The following is a description of a gene set: Mouse Gene Set: GOBP_RESCUE_OF_STALLED_RIBOSOME studied in species Mus musculus A process of translational elongation that takes place when a ribosome has stalled during translation, and results in freeing the ribosome from the stalled translation complex., and this is the list of marker genes: Gigyf2, Pelo, Cdk5rap3, Tcf25 (transcription factor 25 (basic helix-loop-helix)), Mrpl58, Ankzf1, Ufl1, Ufsp2 (UFM1-specific peptidase 2), Skic2, Rnf14, Abce1, Skic8, Rack1, Elac1, Skic3, Ltn1, Klhdc10, Ascc2, Hbs1l, Usp10, Trip4, Rnf25 (NCBI Gene Id 80388), Ptrh1, Gcn1, Ddrgk1, Saysd1, Mtres1, Eif4e2, Trnt1, Zfp598, Ascc3 (activating signal cointegrator 1 complex subunit 3), Gtpbp2, Mtrfr, Rchy1 (NCBI Gene Id 68098), Nemf